The following is a description of a gene set: The regulated release of neurotransmitter from the presynapse into the synaptic cleft via calcium-regulated exocytosis during synaptic transmission. studied in species Mus musculus Mouse Gene Set: GOBP_NEUROTRANSMITTER_SECRETION, and this is the list of marker genes: Nrxn3, Rab3a, Camk2a, Sv2b, Stxbp2, Scrib, Ppp1r9a, Snap25, Ntrk2, Pdzd11, Cacna1a, Lin7c, Rph3al, Kcnj8, Trim9, Cacnb4, Ptprn2, Rab3gap1, P2rx2, Hcrt, Ngf, Brsk1 (BR serine/threonine kinase 1), Abcc8, Efr3a, Braf, Cspg5, Fmr1, Htr1b, Syt10, Slc30a1, Stx2, Snca, Dtnbp1, Prkaca, P2ry2, Grik5, Erc2, Cacna1d, Doc2b, Prkcg, Gpr158, Prepl, Vamp1, Syn3, Slc38a2, Ptger4, Git2, Fbxl20, Pak1, Cplx4, Stxbp5, Cacna1e, Ctbp2, Htr1d, Git1, Dnm1l, Syde1, Syt5, Slc18a3, Syp, Syt4, Stx1b, Syt9, Cacna1b, Nr4a1, Rph3a, Gper1, Kcnc4 (potassium voltage gated channel, Shaw-related subfamily, member 4), Rab5a, Vps18, Syt13 (synaptotagmin XIII), Ppfia2, Snap47, Syt7, Cplx3, Fbxo45, Ppfia3, P2ry1, Tprg1l, Lrrk2, Best1, Tspoap1, Edn3, Syn2, Baiap3, Rims1, Rims2, Mctp1, Xbp1, Gpr151 (NCBI Gene Id 240239), Unc13a, Rap1a, Ncs1, Syngr3, Micu3, Cplx1, Vamp2, Synj1, Snap91, Cadps2, Mef2c, Slc6a9, Rimbp2, Stx19, Stxbp1, Syt1, Kcnh1, Atp2a2, Unc13c, Npy1r, Htr2c, Snap23, Psen1, Drd4, Nrxn2, Stx4a, Prkca, Pclo, Syt2, Snapin, Chrna3, Nf1, Adora2a, Doc2a, Stx11, Snap29, Napa, Cadps, Prkcb, Ppt1, Prrt2 (NCBI Gene Id 69017), P2rx7, Rhot1, Pnkd, Unc13b, Tacr2, Sncaip, Dvl1, Cask, Lin7b, Rims4, P2rx1, Stxbp3, Syt11, Cplx2, Bglap, Slc4a8, Nlgn1, Htr6, Grm8, Osbpl2, Sv2c, Syt8, Ggcx, Kcnc3, Rap1b, Syn1, Septin5, Rims3, Sv2a, Syt12, Stx1a (syntaxin 1A (brain)), Npy, Asic1, Lin7a, Dgki, Otof, Kmo, Wnt7a, Sncg, Bglap2, Stxbp5l, Erc1 (ELKS/RAB6-interacting/CAST family member 1), Pfn2, Sptbn2, Bcl2l1, Mctp2, Napb, Doc2g, Prkn, Sphk1, Nrxn1, Ica1, P2ry4